The following is a description of a gene set: Genes positively differentially expressed in cell type: CD4+ T cell upon treatment with cytokine: IL-1β in mouse lymph nodes in vivo. Cytokines mediate cell-cell communication in the immune system and represent important therapeutic targets. A myriad of studies have highlighted their central role in immune function, yet we lack a global view of the cellular responses of each immune cell type to each cytokine. To address this gap, the authors created the Immune Dictionary, a compendium of single-cell transcriptomic profiles of more than 17 immune cell types in response to each of 86 cytokines (>1,400 cytokine-cell type combinations) in mouse lymph nodes in vivo. A cytokine-centric view of the dictionary revealed that most cytokines induce highly cell-type-specific responses. For example, the inflammatory cytokine interleukin-1β induces distinct gene programmes in almost every cell type. A cell-type-centric view of the dictionary identified more than 66 cytokine-driven cellular polarization states across immune cell types, including previously uncharacterized states such as an interleukin-18-induced polyfunctional natural killer cell state. Mouse Gene Set: CUI_T_CELL_CD4_IL1B_RESPONSE_UP species: Mus musculus from publication Cui A, Huang T, Li S, Ma A, Pérez JL, Sander C, Keskin DB, Wu CJ, Fraenkel E, Hacohen N (PMID 38057668), and this is the list of marker genes: Flot1, Ctsa, Serinc3, Rab18, Ube2s, Tnfrsf18, Elovl6, Slc49a4, Pgs1, Parp14, Ly6a, Zfp281, Sbno2, Treml2, Psmb10, Txnip, Jund, Stat1, Clic4, Cars1, Eeig1 (estrogen-induced osteoclastogenesis regulator 1), Socs1, Rapgef6, Cdkn2d, Igkc, Socs3, Grk6, Zeb1, Zbp1, Ablim1, Mcl1, Gngt2, Pim1, Psme2, Ifi47, Tapbp, Cd53, Skap2, Tcf7, Traf1, Gramd2b, Satb1, Arap2, Gbp2, Epb41, Chmp4b (NCBI Gene Id 96954), Emb, Trib2, Ddit3, Il21r, Ssh2, Abi3, Apobec3, Crem, Dtx3l, Ifngr1, Sgk1, Psme1, Nfkbia, Ttc39b, Notch1 (NCBI Gene Id 68125), Igfbp4, Runx3, Eif5a, Stat3, Mthfd2, Arid5b, Bcl3, Isg15, Eif1, Gpr146, Kif1b, Mrpl52, Crybg1, Eif2s2, Crlf2 (NCBI Gene Id 57914), Parp9 (NCBI Gene Id 80285), Zfp36, Pja1, Hif1a, Etv6, Gpr171, Ube2d3, Mfsd6, Gadd45b, Rpain, Zfp36l2, Hdac4, Akt2, Arl6ip5, Cblb, Myd88, Cd47, Nars1, Mxd1, Gadd45g, Ly6e (lymphocyte antigen 6 family member E), Arid5a, B2m, Ndrg3, Vars1 (NCBI Gene Id 22321), Tsc22d3, Xaf1, Ubald2, Myl12b (NCBI Gene Id 98057), Cytip, Lpp, Arl5a, Btg1, Cebpb (CCAAT/enhancer binding protein beta), Ppp1r9b, Kbtbd11